The following is a description of a gene set: species: Homo sapiens Human Gene Set: MIR4742_3P Genes predicted to be targets of miRBase v22 microRNA hsa-miR-4742-3p in miRDB v6.0 with MirTarget v4 prediction scores > 80 (high confidence targets). from publication Chen Y, Wang X (PMID 31504780), and this is the list of marker genes: ARID4B, SALL4, GRIN2A, DCBLD2, CXCL10, RRP15, ING2, DR1, ARHGAP21, HSP90AA1, ZNF569, MYO16 (NCBI Gene Id 23026), PARP16, GRB10, KLF6, ZNF71, TMPRSS11F, SLC2A1, CISD2, UBASH3B, USP51, ZNF570, THAP5, DGKE (diacylglycerol kinase epsilon), MYO5C, U2SURP, NKTR, SORBS1, FBXO36, MXD4, EPHA5, RAB3GAP2, PCDH15, TBX15, SRSF3, SCUBE2, BCCIP, ERAP2, ZIC1, TMEM117, LY6E, PRRC1, CLIP3, MAP3K5, GABRB2, KLLN, BRCA1, GTDC1, CLIC1, HECW2, ZDHHC15, MFAP3L, GATA3, ZFY, TDRP, MFSD4A, GCNT1, CHD6, VKORC1L1, CNNM2, PUM1, CYP27C1, TBL1XR1, USP28, PNN, STAG1, PCNP, MTAP, CAMK4, ABCA1, TM9SF2, SPR, GJC1, TMEM123, DPP10, CYB5R4, KRT10-AS1, HECTD2, PRR11, BMP3, TRIM10, MLLT3, ATP11C, WBP4, PREPL (NCBI Gene Id 9581), DSEL, NOL10, CACNG8, RND3, COMMD8, COL10A1, STRADB, NABP2, CHIC2, CHFR, ADAT1, DENND1B, PCIF1, NUFIP2, SMAD6, RAF1, MAPK9, BICC1, SMAD5, SLC4A8, NUFIP1, NAV3, CYRIA (NCBI Gene Id 81553), MRPL30, UBE2F (ubiquitin conjugating enzyme E2 F (putative)), ATP2B1, USP42, PGBD2 (NCBI Gene Id 267002), TRIP11, SLITRK3, SUSD5, HDAC2, AHCTF1, HSPA9, VEGFA, XPNPEP3, CALD1, DOC2A, UBR3, OIP5, NRK, CFAP20DC (NCBI Gene Id 200844), TSC22D2, WNK3, FCF1, CERKL, HOOK3, NOVA1, PDE10A, ZWINT, TSHZ3, EBF1, STK26, BEND6, RTL4, FGF7, TMEM158, EIF4A2, SLIT2, VPS13A, NCK2, UBE2J1, PTGDR, EPB41L2, CYP1B1, KIFBP, LGALS8, IRF2BP2 (NCBI Gene Id 359948), UTY, C4BPA, LRRC8C, PPM1B, CD177, SLITRK1, EARS2, TRIM36, TMEM106C, IFNAR1, MACF1, SRFBP1, TNFRSF1B, CALCR, PSMF1, MBD5, ZDBF2, ABCC2, AKAP5, TRDN, UFL1, GRM5, PDE1C, GRAMD1B, ZBTB10, HLTF (helicase like transcription factor), TBC1D9, TMLHE, ITCH, ZRANB3, PHF14, C9orf78, EPC1, CYP4A22, PGAM5, ZNRF2, MOSMO, LSAMP, ABCG8, PURB, DOCK9, GLYAT, PRKCI, CUX2, NAPG, RIMOC1, WAC, PRND, YEATS2, MCMDC2, MLANA, ELOVL5, CLCN3, ZNF449, ANAPC7, DNAJC13, CNTN6, PAPOLA, CDK2AP1, MAP4K5, NCAM1, GNG12, GHITM, SLC39A6, SLC4A10, DROSHA